The following is a description of a gene set: Genes predicted to be targets of miRBase v22 microRNA hsa-miR-3688-5p in miRDB v6.0 with MirTarget v4 prediction scores > 80 (high confidence targets). from publication Chen Y, Wang X (PMID 31504780) species: Homo sapiens Human Gene Set: MIR3688_5P, and this is the list of marker genes: DUSP8, GPR34, RAI2, FBXW7, CREBRF (NCBI Gene Id 153222), KLHDC10, BNC2, HACE1, SRF, CSPP1, GATA3, HYOU1, TNKS1BP1, SGIP1, LTBP2, TMEM41A, FKBP9, STARD4, WHRN, HSD17B3, DPY19L2, ARID5B, SMARCAD1, KDM7A, AKIRIN1, PDP1, UNC119B, MBNL2, EDEM3, COL27A1, FGF7, SRRM1, AKAP13, RGS17, CLDN10, MYSM1, TGFB2, EFHC2, DMXL2, ISCA2, MFSD14A, RABIF, PSMF1, ZNF436, NRXN1, DPYD, YWHAH, FNDC3A, DNAH14, SCN1A, YAP1, PRKCI, PDE5A, ZFX, PAPPA, EXOC5, MEGF10, RREB1, UBIAD1, MSL2, DUSP7, SPRED2, GALNT1, ADCK1, IKZF2, ZNF780B, GAN, IRGQ, NFIB, ANGPTL1, HSD11B2, CHN2, NFAT5, EPB41L1, CTNNB1, PAN3, KPNB1, MRTFB, USP9X (ubiquitin specific peptidase 9 X-linked), CARF, TLK2, NOXRED1, MRPL30, ZXDB (NCBI Gene Id 7790), ZIC5, PAQR9, IMPG2, CNTLN, BCL11B, RCN1, USH1G, RLN2, NFASC, PRDM1, NAA50, VEGFC, APPBP2, ACTR3B, PDXDC1, EFL1, DMXL1, TNFRSF11B, ARF6, PHTF2, ERAP1, TTL, FAM199X, GLRX5, MIER1, SPRY4, FAM81A, CLIC5 (NCBI Gene Id 53405), UBE3A, SLK, DYRK1A, CD9, EBF3, XKR9, SERTM1, PTPN4, APIP, SH3GLB1, PPM1B, ISL1 (ISL LIM homeobox 1), NRBF2 (NCBI Gene Id 91155), IAH1, DGKZ, ADH5, PPP1R11, LIX1, PPTC7, BBX, CCDC126, METAP2, ZNF131, STAP1, WDR44, IDH1